Given this list of marker genes SCN4A, AMPD3, KCNJ18, CACNA1S, AMPD1, CAV3, STIM1, RRM2B, CHRND, SLC16A1, KCNE3, DBH, GABRA3, TRAPPC11, DMGDH, PGK1, SERPINA6, PFKM (NCBI Gene Id 5215), TMEM126B, here is a description of the gene set: Human Gene Set: HP_INCREASED_MUSCLE_FATIGUABILITY studied in species Homo sapiens Increased muscle fatiguability An abnormal, increased fatiguability of the musculature.